Given this list of marker genes COL1A2 (collagen type I alpha 2 chain), COL1A1, FKBP14, COL5A1, COL3A1 (collagen type III alpha 1 chain), COL5A2, PLOD1, PLOD3, here is a description of the gene set: Human Gene Set: HP_ARTERIAL_RUPTURE studied in species Homo sapiens Sudden breakage of an artery leading to leakage of blood from the circulation. Arterial rupture